The following is a description of a gene set: studied in species Mus musculus Human Gene Set: BRUINS_UVC_RESPONSE_VIA_TP53_GROUP_D from publication Bruins W, Bruning O, Jonker MJ, Zwart E, van der Hoeven TV, Pennings JL, Rauwerda H, de Vries A, Breit TM (PMID 18195040) Phosphorylation is important in p53-mediated DNA damage responses. After UV irradiation, p53 is phosphorylated specifically at murine residue Ser389. Phosphorylation mutant p53.S389A cells and mice show reduced apoptosis and compromised tumor suppression after UV irradiation. We investigated the underlying cellular processes by time-series analysis of UV-induced gene expression responses in wild-type, p53.S389A, and p53(-/-) mouse embryonic fibroblasts. The absence of p53.S389 phosphorylation already causes small endogenous gene expression changes for 2,253, mostly p53-dependent, genes. These genes showed basal gene expression levels intermediate to the wild type and p53(-/-), possibly to readjust the p53 network. Overall, the p53.S389A mutation lifts p53-dependent gene repression to a level similar to that of p53(-/-) but has lesser effect on p53-dependently induced genes. In the wild type, the response of genes to UV irradiation was strictly biphasic. The early stress response, from 0 to 3 h, results in the activation of processes to prevent the accumulation of DNA damage in cells, whereas the late response, from 12 to 24 h, relates more to reentering the cell cycle. Although the p53.S389A UV gene response was only subtly changed, many cellular processes were significantly affected. The early response was affected the most, and many cellular processes were phase-specifically lost, gained, or altered, e.g., induction of apoptosis, cell division, and DNA repair, respectively. Altogether, p53.S389 phosphorylation seems essential for many p53 target genes and p53-dependent processes. Category D genes: p53-independent genes whose expression in the absence of S389 phosphorylation is similar to loss of TP53 in MEF (embryonic fibroblast) cells in response to UV-C irradiation., and this is the list of marker genes: PLVAP, ABCB11, ATP6AP2, PTK2, MIA, LMNTD1, TCAM1P, DUSP10, COPB1, BLK, ALDH5A1, HDHD5, ONECUT1, EFCAB15P, FMOD, FHAD1, FMO2, MZT1, CCSER2 (coiled-coil serine rich protein 2), CSMD3, GSK3B, APPL2, LGR5, SEPTIN3, PAX5, C16orf90, PRKG2, PPP1R12B, GJB3, ZDHHC3, PUS3, CNFN, RAB3D, MYOG, AZIN1, TSC22D2, SH3PXD2A, KCNA3, RHD, CHRNA6, RBM25, SREBF2, SH3BGR, TRDN, KERA, CPA1, CCK, AQP11, UBE2O, PHACTR1, TRIM59, KDM5D (lysine demethylase 5D), KIF26B, GGTA1, UBA5, CARD11, PHKA2, NR1D2, IZUMO3, RHBG, EARS2, IPO4, C8orf82, OCA2, FADS1, FBXO32, DUSP23, DDX21, UXS1, SPATA9, SPAG5, ATP1B2, DMD, LUC7L2, NEFM, TRIP10, CD48, SLC30A1, PLCB2, CD2, PDPN, OSBPL3, CYP1A2, INAFM1, ALDH1B1, C19orf18, AMIGO1, VPS50, TNFRSF4, CYFIP2 (NCBI Gene Id 81032), CCL2, PITX3, CHRNG, FAM9A, OSMR, NCBP3, SNX9, BLOC1S1, SOCS6, VEGFC, HHATL, TMCC2, ADISSP, CBX6, KCNMA1, ZFP14, RBM34, PRDM4, SNAPC1, ENPP3, ARHGEF10L, SPMAP2, LRRC15, CFLAR, SNORA64, LRRC8E, SAG, TNFSF13B, MFSD6, MACROD1, GNAT1 (G protein subunit alpha transducin 1), CTSL, ZBTB8A, AKR1C4, CCL7, CITED4, SPHKAP, SLIT2 (slit guidance ligand 2), ARRDC2, PLOD3, RNF122, ADIPOQ, TMEM176A (transmembrane protein 176A), MYO1A, B3GALT1, ADM, POLR3G, DENND1B, HK1, PHKA1, KIF16B, SLC9A2, CYS1, CABP1, PXDN, UBE2QL1, RUNX3, ZC3H13, NRARP, KLHL42, CBLN2, GRK2, ZFP92, CACUL1, B3GALNT1, SERPINA1, LBX1, BICDL1, LAT2, FAM151B, SLC20A2, CRYGC (crystallin gamma C), GSDMD, MID1IP1, RAB15, PARN, PGM2, KDELR2, CHIA, CRMP1 (NCBI Gene Id 1400), DDX3X, SLC12A9, APOF, TGFBR3, TEKT5, CPE, SRCIN1, BMI1, SDR39U1, TPI1, RBM20, GADD45B (NCBI Gene Id 4616), KRT2, PITPNC1, NR2E3, HOOK1, MALL, EXOSC6, C22orf39, FCGR2B, HEMGN, NDOR1, IL2RA, DNM1L, BOC (BOC cell adhesion associated, oncogene regulated), LGALS3, HSPB7, PHGDH, LAMA5, ITPR2, SGCB, ZRANB2, DNAJC10, TMEM35A, GDF10, FBXW11, EFNA2, ZNF267, CTPS1, DBIL5P, SLC32A1, TXNRD3 (NCBI Gene Id 93415), NKTR, FCHO1, SLC17A9, AGO2, VDAC1, PRL, TADA3, DIAPH2, RARA, ETV4, PRPF3, LTBP1, STBD1, PRUNE2, FLACC1, NOPCHAP1, CES2, EXTL2, TRMT13, CLXN, PLEKHA3, MORN1, RNF138, PPP1CB, CD79B, TUNAR, MBP, SPEN, STT3A, SPOPL, BCL2A1, SLC22A23, USP32, CCDC57, RNF121, ENHO, OLFML2B, GAPDH, CALCRL, ADGRA2, SLN, TRAK1, TIPRL, ARIH1, PDCD1LG2, BID, TBX20 (T-box transcription factor 20), PHKG1, EXOC6B, SYNPO2L, TTYH1, SCAPER, TMEM170A, SCGB3A1, ARK2C, SMIM23, KRT84, SLC52A2, ARHGAP45, FNDC8, FAM107B, TIAM1, GABRA5, ZBTB22, GTPBP4, CFAP126, SEMA3A